Given this list of marker genes PF4V1, PPBP (NCBI Gene Id 90374), TFF2, YARS1, CXCL13, ITCH, CCL28, CXCL5, PF4, CCL27, CX3CL1 (NCBI Gene Id 6376), CXCL11, CXCL8, CXCL12, CXCL10, CXCL6, CXCL9, here is a description of the gene set: Human Gene Set: GOMF_CXCR_CHEMOKINE_RECEPTOR_BINDING Binding to a chemokine receptor in the CXCR family. species: Homo sapiens